The following is a description of a gene set: Dopamine receptors Human Gene Set: REACTOME_DOPAMINE_RECEPTORS studied in species Homo sapiens, and this is the list of marker genes: DRD3, DRD5, DRD2, DRD1, DRD4